Given this list of marker genes Ncl, Rpf1, Cavin1, Imp4, Lipe, here is a description of the gene set: Binding to an unprocessed ribosomal RNA transcript. species: Mus musculus Mouse Gene Set: GOMF_RRNA_PRIMARY_TRANSCRIPT_BINDING